Given this list of marker genes MTR, MADD, AP1S2, GIMAP8, SETD1B, IFIT1B, SLC26A11 (NCBI Gene Id 65011), ESCO2, SIPA1, NAPSA, HAGHL, P2RY10, PIK3R6, ANAPC15, CMA1, SLC44A1, PPP1R12C, CD79B, TSC22D4, ERLIN1, PTRH2 (peptidyl-tRNA hydrolase 2), CD3D, NIN, NUDT14, IER5, GGPS1 (NCBI Gene Id 9453), PROM1, FCHO1, SYTL2, WDR5, UQCRHL, STIM2, HLA-DMA, KMT2D, TAP2, ADAMTS10, CAD, CRISPLD2, SUSD6, CEP19, RASSF7, MBNL3, ZSWIM8, GSTM3, SNRNP27, PLOD1, ATP2B1, ADGRG3, RAB37, RAB32, COMMD8, PLSCR1, H2AJ, SELENOO, LY86, MRPL52 (mitochondrial ribosomal protein L52), SH2D1A, PHF14, ARHGDIA, RRAGC, LRRC45, SOD1, TLE6, PFDN4, ABTB1, KBTBD11, TMEM170B, SAFB2, ITGA2B, BTLA, PPP4C, TSR2, TIAM1, JPT1, RING1, FOSB, KIF22, CIP2A, IST1, MAGOH, NEDD8, PPA1, ING1, LRWD1, MLF2, CASP4, ZCCHC8, HDAC9, TOP1, EXOC3L2, MMS22L, CRYBA4, MCU, DPP4, GBP7, CD82, SLC44A2, TFPT, PRG3, SMOX (NCBI Gene Id 54498), CENPU, DGAT2, PF4, LRP8, SGSH, RAB3D, PSME2, UBE2I, PDE7B, RPL4, ZDHHC13, DENR, SELENOH, ABCA7, CCDC82, BCL11B, TMEM128, STAT4, SLC2A6, PABPN1, SLBP, ARID3B, MGAT4A, BLOC1S1, CEBPD, NDST2, MSL1, SIDT2, SRSF11, DEPDC1, ENC1, SPEN, SNAP23 (NCBI Gene Id 8773), FASLG, TRIM59, RNASEL, HNRNPL, B4GALT1, HK1, ZNF445, LCK, TOB2, GAS6, IFI35, VAMP8, RPS3A, NFKB2, IKBKB, SATB1, RPL18A, TOX3, TRAFD1, RAPGEF2, GIMAP4, CD93, DTL, PSME1 (NCBI Gene Id 5720), CTNND2, CCDC107, ANXA6, POLD1, RAPGEF1, SPINT2, CYLD, AHRR, CFB, GRAMD1B, MRPL41, SERPINB2, TBX21, TAL1, MTCP1, TEX30, GNG2, STRADA, SLC11A1, HNRNPD, GATD3, TOP3B, KMT2A, C6orf89, ZMAT2, CRLF3, PAN3, GPR18, OFD1, MLEC, PBRM1, GP9, NEU1, NCR1, ARHGEF37, TNFSF10, RASGRP1, IKZF3, SEC61G, SLC27A4, IRAK2, CNPY3, here is a description of the gene set: IL-10 or IL-6 stimulation of control 129xC57BL/6 murine bone marrow derived macrophages in the presence of LPS. We used microarrays to detail the global programme of gene expression changes in response to IL-6 or IL-10 stimulation in the presence of lipopolysaccharide. BMDMs were isolated from control, IL-6-/-, and IL-10-/- mice on a 129XBL/6 mixed background mice and differentiated in the presence of CSF-1 for 6-7 days. Cells were scraped and plated in 6 well plates at 2x10e6/well. Cells were washed with complete DMEM and rested for 1-2 hr before stimulation with combinations of IL-10 (10 ng/ml), IL-6 (2 ng/ml) or LPS (100 ng/ml) for 45 min or 180 mins. Complete biological replicates were performed. Human Gene Set: GSE5589_UNSTIM_VS_180MIN_LPS_AND_IL10_STIM_MACROPHAGE_DN Genes down-regulated in bone marrow-derived macrophages: untreated (0 min) versus IL10 and LPS (180 min). species: Homo sapiens from publication El Kasmi KC, Holst J, Coffre M, Mielke L, de Pauw A, Lhocine N, Smith AM, Rutschman R, Kaushal D, Shen Y, Suda T, Donnelly RP, Myers MG Jr, Alexander W, Vignali DA, Watowich SS, Ernst M, Hilton DJ, Murray PJ (PMID 17114459)